Given this list of marker genes GNG8, GNG3, GNG5, GNAQ, P2RY1, GNG12, GNA14 (NCBI Gene Id 9630), GNB4, GNB1, GNB2, GNG7 (NCBI Gene Id 90274), GNGT2, GNG13, GNG10, SRC, GNB5, GNGT1, GNB3, MAPK14, GNG2, GNA11, GNG11, GNA15, GNG4, PLA2G4A, here is a description of the gene set: Co-activation of P2Y1 and P2Y12 is necessary for complete platelet activation. P2Y1 is coupled to Gq and helps trigger the release of calcium from internal stores, leading to weak and reversible platelet aggregation. P2Y12 is Gi coupled, inhibiting adenylate cyclase, leading to decreased cAMP, a consequent decrease in cAMP-dependent protein kinase activity which increases cytoplasmic, necessary for activation.<br> In activated platelets, P2Y12 signaling is required for the amplification of aggregation induced by all platelet agonists including collagen, thrombin, thromboxane, adrenaline and serotonin. P2Y12 activation causes potentiation of thromboxane generation, secretion leading to irreversible platelet aggregation and thrombus stabilization. Reactome Pathway: ADP signalling through P2Y purinoceptor 1 species: Homo sapiens part of: Signal amplification